Given this list of marker genes GNAI1, HS1BP3, CYP27B1, GP1BA, GLG1 (golgi glycoprotein 1), CHEK2, HPRT1, LAMP5, GCNT4, CCDC86, ATIC, EIF3D, ENPP5, CHADL, CD200R1, FMN2, APOL5, ASTL, HMBS, GNA13, GNPAT, ANKRD24, ASPRV1, FAM209B, C6orf141, GPR37, CDC14C, ATG3, DNAJC1, CORO1A, EOGT, BRD7P3, GRB7, ASAP3, DNAJC24, GPR137B, COQ10A, ADAMTSL4, C6orf58, FAM89B, FGF12, FTSJ3, GARIN3, LINC02868, EPB41, PSME3IP1, GMPR2, AMOT, ATP5PF, HSDL2, ACVR1 (activin A receptor type 1, NCBI Gene Id 90), GPATCH3, CAPN7, BAG2, CDO1, EPGN, ARMC7, PLAAT5, GSTM1, HPCAL4, CIAO2A, GGTLC1, EPB41L5, G6PD, CSTL1, CHORDC1, ADAMTS16, DVL3, MYRFL, HAUS5, CAMK4, CSF3R, DNAJB2, CAMSAP1, FOXE1, GABRR1, AMD1, ETV5, DTD1, SHLD1, NELFB, ALKBH8, FSHR, ATF7IP2, DRC7, CTCFL, GALNT13, HIPK3, FAM90A1, DGAT1, ZFHX3, HSPB7, CD226, EIF4EBP2, GLYAT, GRPEL1, CFAP184, DENND2C, CTSF, ATP6V1F, BRIP1, C1S, DAB1, CIMIP5, CKS2, EPHA4, DNAJC5B, CTSD, FOSL1, ABHD17A, ADAM10, CASP7, CNKSR3 (NCBI Gene Id 154043), DIMT1, FECH (NCBI Gene Id 2235), GTF2A1, ABCC2, ARL13A, GCK (glucokinase), PGGHG, CTLA4, COX16, ATP5IF1, GFRA3, DCAF8L2, IBA57, ARL13B, GPRC5A, NOCT, GNAQ, ADGRG2 (NCBI Gene Id 10149), CCDC47, GINS1, ALG8, GHR, CTSB, FAM181A, SDHAF3, FKBP4, BNIP2, HCAR3, CASP4, FA2H, C1QTNF2, DRD2, RPP38-DT, CDH1, C12orf75, GPR4, CASP8AP2, CLN3, C1QL4, COG5, HOOK3, ACOX3, DNAJC9, ABHD17B, CXCL11, B3GALT5-AS1, CDK4, ANKRD42, DIPK2A (divergent protein kinase domain 2A), CDKN1C, TMA16, DDX39B, DHRS7B (NCBI Gene Id 82068), FEZ2, HSP90AA2P, BHMT2, COX7C, C16orf54, GLRA3, EPHX3, EYA1, CCDC61, CERCAM, NYAP1, MFSD12, HSD3B7, AGT, CHML, CALHM6, ANXA2P2, ALDH16A1, BAG5, ATP13A2, MIX23, BUB3, ADGRG1, ANKH, GAL3ST3, GIN1, IFTAP, HNRNPM (NCBI Gene Id 4670), RTL8C, GRIA2, AMZ2, here is a description of the gene set: species: Homo sapiens Human Gene Set: GSE22601_DOUBLE_NEGATIVE_VS_DOUBLE_POSITIVE_THYMOCYTE_UP from publication Dik WA, Pike-Overzet K, Weerkamp F, de Ridder D, de Haas EF, Baert MR, van der Spek P, Koster EE, Reinders MJ, van Dongen JJ, Langerak AW, Staal FJ (PMID 15928199) T cells develop from progenitors that migrate from the bone marrow into the thymus. Thymocytes are subdivided roughly as being double negative (DN), double positive (DP), or single positive (SP), based on the expression of the CD4 and CD8 coreceptors. The DN stage is heterogeneous and can be subdivided into four distinct subsets in mice based on the expression of CD44 and CD25. In human, three distinct DN stages can be recognized: a CD34+CD38−CD1a− stage that represents the most immature thymic subset and the consecutive CD34+CD38+CD1a− and CD34+CD38+CD1a+ stages. Human DN thymocytes mature via an immature single positive (ISP CD4+) and a DP stage into CD4+ or CD8+ SP T cells that express functional T cell receptors (TCR) and that exit the thymus. In this study, gene expression was measured in each of these nine stages. Genes up-regulated in thymocytes: double negative versus double positive.